The following is a description of a gene set: Mouse Gene Set: GOBP_REGULATION_OF_LONG_TERM_SYNAPTIC_POTENTIATION Any process that modulates the frequency, rate or extent of long-term synaptic potentiation. studied in species Mus musculus, and this is the list of marker genes: Nos1, Cyp46a1, Slc18a3, Abl1, Zdhhc2, Sqstm1, App, Shank3, Ythdf1, Prkar1b, Nlgn3, Drd2, Adora1 (NCBI Gene Id 98749), Cx3cr1, Fam107a, Rab3a, Eif2ak4, Drd1, Paip2 (polyadenylate-binding protein-interacting protein 2), Creb1 (cAMP responsive element binding protein 1), Nf1, Tyrobp, Ager, 2510002D24Rik, Ptpn5, Mme, Prnp, Shisa7, Crtc1 (CREB regulated transcription coactivator 1), Igsf11, Nrgn, Adora2a, Pirb, Reln, Lgmn, Fmr1, Pak1, Apoe, Nsg1, Arc, Cpeb3, Akap5, Adrb1, Chrna7, Fxr1, Epha4, Ptn, Pde9a, Stau1, Nptn, Ephb2, Adcy8, Adcy1, Gsk3b (NCBI Gene Id 98033), Hnrnpk, Ncstn, Ppp1r9a